Given this list of marker genes PIGT (NCBI Gene Id 94004, phosphatidylinositol glycan anchor biosynthesis class T), NT5C3A, CFI, G6PD, ALDOA, CD59, CASK, PIEZO1, PIGA, HELLPAR, CD46, CFH, here is a description of the gene set: Human Gene Set: HP_HEMOGLOBINURIA The presence of free hemoglobin in the urine. Hemoglobinuria studied in species Homo sapiens